Given this list of marker genes TOX4, CDS2, EIF4A3, TOR1B, SP3, PSMD14, SNAPC1, NUP88, PGGT1B, RNF14 (NCBI Gene Id 9604), RPN2, PLEC, ADAM17, RP2, IRF4, ELF4, NSMAF, ATP1B3, VDAC1, CHSY1, IER3, SLC1A5, PLAGL2, TIMELESS, TUBB4B, ZNF200, CYP1B1, IDS, DYNLL1, TNFSF14, AHR (aryl hydrocarbon receptor), HIVEP2, SAFB2, PEX3, S100A11, PNP, EVI2B, MACF1, ATF3, EZH2, SUCLA2, LYSET, POP4 (NCBI Gene Id 10775), PRDX1, BCL10, UBE2D1, EEA1, MRPL19, PPRC1, TSC22D2, ATXN2, CD40LG, HOXB2, PNO1, ZPR1, NUP160, CYCS, HPS5, ZBTB24, RLN2, HNRNPAB, GNAI3, WBP1L, NFYA, EIF2S1, RPA3, FHL2, MAP2K3, BCL2A1, ZNF318, ZNF140, PAF1, CHMP1A, MUTYH, BIK, WDR1, DLEU2, HNRNPF, IFRD1, CLIC1, AHCYL1, SERPINE2, SLC7A5, RAPGEF2, TUBA1A, TP53BP1, ZNRD2, GEM, DUSP2, ADO (NCBI Gene Id 84890), GABPB1 (GA binding protein transcription factor subunit beta 1), LRRN3, IMPA1, SERPINB8, NCBP2, CCT5, IVNS1ABP, TUBA1B, TRA2B, SEC62, RRAS2, IQCB1, RGS10, RANBP2, CD200, ATP2B1, MKLN1, NAB1, NELFE (negative elongation factor complex member E), PKM, SACS, PLP2, PRNP, CCL4, PSMD9, GRAMD4, SLC5A3, RRP7A, FEZ2, SUB1, PSMD7, TNFRSF1A, RBM14, ISG20L2, BLZF1, SRR, ACSL1, TAF1B, TEX261, DUSP14, EZR, CDC42EP3, PAQR3, SYNCRIP, TNF, GPM6B, NFKB1, TMEM243, UMPS, FASLG, HOPX, COX17, FH, REL, IL2, ZNF267, IPO7, GFI1, TNFRSF1B, IL1B, DUSP5, UNG, PTPN22, CD58, DUSP4, SPRY1, VAPA, CSTB, CAND1, LPCAT1, WDR47, FEM1B, SLC25A16, ARG2, AGO2, YWHAE, RANBP9, CASP10, PPP2CA, UBA2, URB2, NOP56, SH2D2A, RHOG, TRAF1, TXNDC9, NLRP3, HINFP, LRRFIP1, DAAM1, HNRNPA0, DIMT1, MBNL1, ZC3H13, SS18L1, LTBP4, SPRY2, MINPP1, GNG5, GNL2, KIFBP, HRAS, FAM131A, ACTG1, FEN1, IL18RAP, NUP188, MATK, PGAM1, KLHL9, here is a description of the gene set: Gene expression profile of LysMCre/Cre and KLF2∆/∆ primary peritoneal macrophages following 6 hours of LPS treatment. We used microarrays to detail the global program of gene expression following LPS stimulation of LysMCre/Cre and KLF2∆/∆ primary peritoneal macrophages. We identified distinct classes of genes that were altered following LPS stimulation. Genes down-regulated in peritoneal macrophages treated with LPS: wildtype versus KLF2 knockout. from publication Mahabeleshwar GH, Kawanami D, Sharma N, Takami Y, Zhou G, Shi H, Nayak L, Jeyaraj D, Grealy R, White M, McManus R, Ryan T, Leahy P, Lin Z, Haldar SM, Atkins GB, Wong HR, Lingrel JB, Jain MK (PMID 21565532) species: Homo sapiens Human Gene Set: GSE26727_WT_VS_KLF2_KO_LPS_STIM_MACROPHAGE_DN